The following is a description of a gene set: species: Homo sapiens Human Gene Set: REACTOME_FREE_FATTY_ACID_RECEPTORS Free fatty acid receptors, and this is the list of marker genes: FFAR2, GPR31, FFAR4, FFAR1, FFAR3